The following is a description of a gene set: Human Gene Set: HP_NASAL_REGURGITATION studied in species Homo sapiens Nasal regurgitation Regurgitation of milk through the nose., and this is the list of marker genes: TUBB6, MYO9A, SYT2, SNAP25, AGRN, TOP3A, SLC18A3, VAMP1, UBB, GRHL3, CHAT (NCBI Gene Id 1103), SLC5A7, COL13A1, SLC25A1